The following is a description of a gene set: The set of behavioral processes that occur as part of the general adaptation syndrome, the response of the body to a strong, stressful stimulus. species: Homo sapiens Human Gene Set: GOBP_GENERAL_ADAPTATION_SYNDROME_BEHAVIORAL_PROCESS, and this is the list of marker genes: PENK, ZNF212, TMEM74, CRHR1, HCN1